Given this list of marker genes Snhg8, Aldoa, Slc25a3, Atp5f1d, Gimap7, Sp110, Rps20, H2aj, Gimap3, Psme2, Psmb8 (proteasome (prosome, macropain) subunit, beta type 8 (large multifunctional peptidase 7)), Bola2, Rbm3, Antkmt, Cd82, Hsp90b1, H2-K1, Bst2, Mif4gd, Tnfrsf18, Ms4a4b, Cyba, Rpsa, Oaz1, Epsti1, Fis1, Gmfg, Bloc1s1, Anxa2, Gabarap, Krtcap2, Smpdl3a, Thap3, Lime1, Efhd2, Comt, Taf10, Tmed9, Rexo2, Fxyd5, S1pr4, Lsm4, Entrep3, Selplg, Pkp3, Cirbp, Sec11c, AW112010, Rac2, Nap1l1, Cd74, Rplp0, Psmb10, Rpl8, Park7, Cd37, Pgls, Gimap5, Mettl23, Pglyrp1, Pa2g4, Gpr18, Rnaset2b, Cxcr3, S100a4, S100a6, Arpc3 (NCBI Gene Id 80396), Rpl13, Apbb1ip (amyloid beta precursor protein binding family B member 1 interacting protein), Ctss, Eif3i, Capg, Irf1, Smco4, Prr13, Chd3, Gapdh, Eif3f, Ly6a, Srsf5, Vmp1, Ifi203, Hspe1, Tle5 (NCBI Gene Id 14797), Cxcr6, Cuta, Plac8, Rps10, Arl6ip5, Bcl2a1b, Pabpc1, Izumo1r, Fth1, Smad7, Capzb, Socs3 (suppressor of cytokine signaling 3), Myl12b, Klrd1, Rnf138, Nme2 (NME/NM23 nucleoside diphosphate kinase 2), Srgn, Fyb1, Ifi27, Nsa2, H2-Ab1, Wdr89, Ssbp4, Hsd17b8, Tpt1, Tpst2, Ptpn1, Lamtor4, Ybx1, Ndufs7, Thy1, Tax1bp1, Rps5, Scamp3, Jund, Use1, Syngr2, Tmem234, Tmem160, Tmsb10, Klf2, Nkg7, Ctsz, Arl4c, Prdx5, Cfl1, Nsd3, Gstp3, Nop53, Spr, Swi5, Npm1, Ssr4, Ms4a6b, Tln1, Gm6402, Chmp4b, Csnk2b, H2-D1 (NCBI Gene Id 547343), Ostf1, Dnajc9, Ccdc85b, AB124611, Ptpn18, Aurkaip1 (aurora kinase A interacting protein 1), Crip1, Sf3b2, Lat, S100a11, Gpx4, Ly6c2, Hint1, Scand1, Vps28, Nt5c, Psmb9, Mrpl52, Xrn2, Runx3, H2-Q4, Ndufb7, Ankrd12, Apobec3, Ltb, Ly6e, Zfas1, Cst7, Ctla2a (NCBI Gene Id 13024), Il7r, Atp5mc2, Psme1, Rabac1, Arhgdia, Hcst, Cdk2ap2, Il2rb, Cotl1, Junb, Chmp2a, Adrm1, Eif5a, Stat3, Eif3k, Srrm2, Rpl3, Kbtbd11, Plaat3, Psmb1, Rpl18, Shisa5, Crlf2, Mycbp2, Ccl5, Polr2e, Mndal, Rack1, Tpm3, Tagln2, Batf, Drap1, Tspo, Rps3, Snrpc, B2m, H2-Aa, Aprt, Tpr, Fbl, Wdr83os, Ly6d, Dnajc15, Micos13, Rpl13a, Calr, Gramd2b, Arpc1b, Lamtor1 (late endosomal/lysosomal adaptor, MAPK and MTOR activator 1), Sft2d1, Gstp1, Rinl, Bsg, here is a description of the gene set: species: Mus musculus Mouse Gene Set: TABULA_MURIS_SENIS_THYMUS_DN4_THYMOCYTE_AGEING from publication Tabula Muris Consortium (PMID 32669714)